The following is a description of a gene set: Habitual insertion of foreign bodies into bodily orifices. Human Gene Set: HP_POLYEMBOLOKOILAMANIA Polyembolokoilamania species: Homo sapiens, and this is the list of marker genes: DEAF1, MYT1L, RAI1 (NCBI Gene Id 6600), FLII, IQSEC2